Given this list of marker genes GPRASP1, PSMB6, PSMB5 (proteasome 20S subunit beta 5), ALDOA, CYTIP, ITIH2, NPC2, CDH17, MDH1, CLU, PSMA4, C2, CP, DUT, RACK1, PSMA7, FN1, MSLN, PSAT1, CD81, ENPP2, GSTO1, CTSD, TALDO1, TUT1, APP, CDC25B, GOT2, PEBP1, YWHAZ, RALYL, CFB, PHACTR4, PGK1, CTSH, SDC1, CX3CL1, RAN, CTSB, PRSS2, COL18A1, CREG1, SDC4, LDHA, LGALS3BP (NCBI Gene Id 3959), DHFR, CTSA, ACTB, TPI1, CST3, AGRN, TPT1, PGAM2, BGN, CANT1, CLSTN1, CDH1, IGFBP4, CTSV, GSTM5, FDPS, ANXA2, PSMA6 (NCBI Gene Id 87553), RPL10A, CHAF1A (NCBI Gene Id 107985297), PRDX1 (NCBI Gene Id 5052), PSMB7, KCTD7, HSP90AB1 (NCBI Gene Id 3326), TIMP2, GOT1, AKR1A1, PPIB, VCAM1, ENO1, MDH2, here is a description of the gene set: Non-small cell lung cancer (NSCLC) cells with somatic mutations in K-ras recruit to the tumor a variety of cell types (hereafter collectively termed stromal cells) that can promote or inhibit tumorigenesis by mechanisms that have not been fully elucidated. Here, we postulated that stromal cells in the tumor microenvironment alter the tumor cell secretome, including those proteins required for tumor growth and dissemination, and we developed an in vitro model to test this hypothesis. Coculturing a murine K-ras mutant lung adenocarcinoma cell line (LKR-13) with a murine lung stromal cell (macrophage, endothelial cell, or fibroblast) enhanced stromal cell migration, induced endothelial tube formation, increased LKR-13 cell proliferation, and regulated the secretion of proteins involved in angiogenesis, inflammation, cell proliferation, and epithelial-to-mesenchymal transition. Among these proteins, CXCL1 has been reported to promote NSCLC development, whereas interleukin-18 (IL-18) has an undefined role. Genetic and pharmacologic strategies to inhibit CXCL1 and IL-18 revealed that stromal cell migration, LKR-13 cell proliferation, and LKR-13 cell tumorigenicity required one or both of these proteins. We conclude that stromal cells enhanced LKR-13 cell tumorigenicity partly through their effects on the secretome of LKR-13 cells. Strategies to inhibit tumor/stromal cell interactions may be useful as therapeutic approaches in NSCLC patients. Proteins secreted in co-culture of LKR-13 tumor cells (non-small cell lung cancer, NSCLC) and MHS stroma cells (macrophages). from publication Zhong L, Roybal J, Chaerkady R, Zhang W, Choi K, Alvarez CA, Tran H, Creighton CJ, Yan S, Strieter RM, Pandey A, Kurie JM (PMID 18757440) species: Mus musculus Human Gene Set: ZHONG_SECRETOME_OF_LUNG_CANCER_AND_MACROPHAGE